Given this list of marker genes Nedd9, Ifng, Gpr68, Il20, Il23a, Ninj1, Ccl5, Itgb3, Ccr1, Ccr1l1, Csf1r, Car2, Traf6, Creb1, Il12b, Tmem64, Ocstamp, Ccl9, Eeig1, Rptor, Gsk3b, Ccl3, Asxl2, Fos, Notch2, Dlk1, Csf1, Tnfsf11, Slc9b2, Il17a, Trem2, Ppp3ca, Klf10, Ppargc1b, Gnas, Pou4f1, Tnfrsf11a, Tyrobp, Tnf, Pou4f2, here is a description of the gene set: Mouse Gene Set: GOBP_POSITIVE_REGULATION_OF_OSTEOCLAST_DIFFERENTIATION Any process that activates or increases the frequency, rate or extent of osteoclast differentiation. studied in species Mus musculus